Given this list of marker genes Zfp426, Pcdha12, Cplx3, Efna5, Fmr1, Cul4b (cullin 4B), Lrrk1, Kcnmb1 (potassium large conductance calcium-activated channel, subfamily M, beta member 1), Triobp, Adhfe1, Mapk6, Pcdha5, Gas2l3, Elfn1, Adcy9, Nectin1, Fam163a, Antxr2, Camta1, Slc26a7, Maneal, Vstm5, Rnf38, Luzp1, Pcdhb7, Kctd15, Pcdha8, Ccdc191 (coiled-coil domain containing 191), Znrf3, Fam169b, Cyp1b1, Dclre1b (DNA cross-link repair 1B), Tmem47, Fat3, Nfatc3, Gnb1, Cyb5b, Flrt2, Hhip, Ankrd29, Pcdha3, Cul5, Ctns, Scn3b, Lrrc8a, Ankrd50, Jcad, Rhebl1, Pcdha6 (protocadherin alpha 6), Rorb, Inhbb, Ino80, Tnrc18, Wipf3, Tnfrsf1b, Cacul1, Bnc2, Impdh1, Srms, Nup58, Amotl1, Eml3, Clec4d, Nkain2, Slc35d2, Syncrip, Osbpl9, Cbx7, Rab3ip, Lekr1, Onecut3, Mapk10, Adgra1, Kat7, Pou2f2, Cep104, Pcdha7 (protocadherin alpha 7, NCBI Gene Id 12939), Clip4, Tnrc6b, Pip4k2a, Fbxo30, Clock, Pcdhac1, Ark2n, Mex3a, Tfdp2 (transcription factor Dp 2), Ncor1, Zfp696, Crh, Iglon5, Pcdha2, Rnase2a, Bend3, Gm4847, Gcnt4, Arhgef9, Abl2, Tmem38b, Ankle1, Vcf1, Rspo1, Orai2, Trib2, Pate9, Irx4, Fam210b, Srsf6, Zfp14, Zfp641, Pcf11 (PCF11 cleavage and polyadenylation factor subunit), Hyal1, Wnk3, Zdbf2, Gnai3, Kat2b, Usp44, Fgfrl1, Wscd1, App, Kpna3, Smap1, Car10, Ncam1, Ccser2, Ikzf2, Ndnf, Slc46a3, Wdr45b, Elmod2, Adamts10, Lrguk, Rars1, Rrm2b, Pcdha9, Tet2, Gm9, Dsel, Tmem255a, Chst1, Grm1, Asic2, Dtna, Nin, Cnga4, Enpp1, Bptf, Tmbim6, Bcas3, Gria2, Arpp21, Ino80d, Ttll1, Adamtsl3, Usp14, Slc30a7, Mbd5, Mmp21, Dnajc28, Acbd5 (NCBI Gene Id 74159), Gabbr2, Pcdha10, Itsn2, Mtmr14, Abraxas1, Yeats2, Dmrtc1a, Npas2, Chst11, Metrnl, Grik2, ENSMUSG00000121861, Cnga2, Astn1, Keg1, Pcdha4, Adgrf2, Gls, Gm4841, Hbp1, Tbrg4, Rbms2, Ankfy1, Mro, Fblim1, Npas3, Enpp6, Zfp936, Daam1, Cacna2d2, Arfgef1, Lmln, Apela, Tgfbrap1, Rgs4, Auh, Snap25, Kcnq2, Mobp, Igf2, Slc6a19, Tppp, Rnf152, Vapb, Sgk1, Pcdha11 (protocadherin alpha 11), Pcdhac2, Bmp7, Pcdha1, Lhfpl6, Akap7, Tead1, here is a description of the gene set: from publication Chen Y, Wang X (PMID 31504780) Genes predicted to be targets of miRBase v22 microRNA mmu_miR_466j, mmu_miR_466m_5p, mmu_miR_669m_5p in miRDB v6.0 with MirTarget v4 prediction scores > 80 (high confidence targets). Mouse Gene Set: MIR_466J_MIR_466M_5P_MIR_669M_5P studied in species Mus musculus